Given this list of marker genes Ppp1cb (NCBI Gene Id 231111), 2210418O10Rik, Dspp, Traf6, Cks1brt, Pdp2, Abca3, Ccne2, Smg8, Epc1, Lrtm1, Zg16, Frem1, Myt1l, H2ax, Pex12, Adamts13 (NCBI Gene Id 279028), Ncam1, Gm14296, Dmp1, Gm13040, Fbxo9, Rabgef1, Nadk2, Foxc1, Nfil3, Zfp970, Pnn (NCBI Gene Id 52618), Zfp128, Itga4, Ssx2ip, Atl2, Zic4, Gaa (glucosidase, alpha, acid), Rimklb, Thumpd1, Cks1b, Cdc27, Dnajc6, Nell1, Hes5, Plp1, Riok3, Taf1, Ect2, Krr1, Sptssb (NCBI Gene Id 66183), Jun, Gne, Nexmif, Adamtsl3, Usp49, Mylk, Ipcef1, Slc27a2, Gm13043, Vezt, Ostn, Camta1, Chrdl1, Usp34, Fut9, Gask1b, Tmem45a2, Alx1, Pramel16, Slc2a13, Pramel31, Kcnc2, Dclk1, Cd164, Jmy, Kcnd2, Ubap1, Gm13057, Gfm2, Shisal1, Pxk, Miga1, Depp1, Dram2, Adtrp, Kif1c, Plxnb1, Pank3, Irf2bpl, Gpalpp1, Sla2, Slc6a2, Cachd1, Cbx5, Pex5l, Rab5c, Gdi2, Nudcd1, B3galnt1, Pstpip2, Vkorc1l1, Srsf2, here is a description of the gene set: Genes predicted to be targets of miRBase v22 microRNA mmu_miR_501_5p in miRDB v6.0 with MirTarget v4 prediction scores > 80 (high confidence targets). species: Mus musculus Mouse Gene Set: MIR_501_5P from publication Chen Y, Wang X (PMID 31504780)